The following is a description of a gene set: species: Homo sapiens Human Gene Set: HP_RICKETS Rickets is divided into two major categories including calcipenic and phosphopenic. Hypophosphatemia is described as a common manifestation of both categories. Hypophosphatemic rickets is the most common type of rickets that is characterized by low levels of serum phosphate, resistance to ultraviolet radiation or vitamin D intake. There are several issues involved in hypophosphatemic rickets such as calcium, vitamin D, phosphorus deficiencies. Moreover, other disorder can be associated with its occurrence such as absorption defects due to pancreatic, intestinal, gastric, and renal disorders and hepatobiliary disease. Symptoms are usually seen in childhood and can be varied in severity. Severe forms may be linked to bowing of the legs, poor bone growth, and short stature as well as joint and bone pain. Hypophosphatemic rickets are associated with renal excretion of phosphate, hypophosphatemia, and mineral defects in bones. The familial type of the disease is the most common type of rickets. Rickets, and this is the list of marker genes: SLC34A3, HNF4A, SLC4A1, ALPL (NCBI Gene Id 249), TJP2, KRAS, CTNS, STAT6, HSD3B7, AKR1D1, FARSB, RAF1, NRAS, ALK, ATP7A, RNU4ATAC, ADAMTSL2, RRM2B, ATP8B1, EHHADH, GATM, CLDN16, CLCN5, FGF23, ABCC6, BAAT, NAB2, NDUFAF6, ADAMTS2, BRAF, FAH, SLC2A2, HRAS, ENPP1, SOX5, ATP6V0A4, HLA-DQB1, DMP1, CYP27B1, ZEB2, VDR, POLRMT, HLA-DQA1, PHEX, CYP2R1, OCRL, SLC34A1